The following is a description of a gene set: studied in species Homo sapiens Genes up-regulated in comparison of naive B cells versus plasma cells from bone marrow and blood. Immune cell-specific expression is one indication of the importance of a gene's role in the immune response. In order to identify such patterns, we set out to broadly profile gene expression in a variety of immune cells. Human Gene Set: GSE22886_NAIVE_BCELL_VS_BM_PLASMA_CELL_UP from publication Abbas AR, Baldwin D, Ma Y, Ouyang W, Gurney A, Martin F, Fong S, van Lookeren Campagne M, Godowski P, Williams PM, Chan AC, Clark HF (PMID 15789058), and this is the list of marker genes: ZNF682, SLA, DCAF17, ZFP36L1, GGA1, DENND4B, MDN1, MRPL39, UNC119B, SLC25A24, HHEX, RPS29, WDR48, NUP205, ARIH1, RADX, NHLRC2, LYST (lysosomal trafficking regulator), MYNN (NCBI Gene Id 55892), GABBR1, UTP14C, DTX4, TPCN1, SMC2, CHL1, MLLT10, PLSCR3, SUPT16H, XYLT1 (xylosyltransferase 1), GMCL1, HLA-DMB, CEP43, VAV3, MS4A1, MRE11, EFCAB14, WDR37, PVRIG, TSEN2, PNRC2, PARG, RPL37A, ARAP2, SOBP, CLEC4A, KIF21B, SART3, NR3C2, SPG7, FBXO28 (F-box protein 28), GSPT2, LTB, DGKZ, BTG1, IRF8, UGDH, TIPRL, SEPTIN9, POLDIP3, NAA40, ZCCHC2 (zinc finger CCHC-type containing 2), STX6, ZNF468, ALKBH1, PKIG, MAVS, CR2, CCP110, STK4, PEG10, HPF1, POT1, VAPB, EGLN2, FCMR, NBPF10, ARHGAP19, TGFBR1, ZNF112, HLA-DMA, LBH, DNAJC16, CD52, HLA-DRB1, ESS2, TPK1, SMAD3, DPYD, SGPL1, R3HDM4, PKIA, CD72, KAT6A, CREM, SELL, FBXO42 (F-box protein 42), RPL27, STAT6, DPPA4, CPEB3, TRIP4, ARHGAP45, OTUD3, PEX7, CD200, MCUB, TRIB2, SGPP1, TCL1A, AKAP11, PLPBP, TIMELESS, RBM8A, ENTPD1, ITPKB, ATP6V1B2, COMMD8, SMARCA2, TERF2, RPS6, PARN, NUP37, SBNO1, CXCR4, VPS72, TRMT2B, KYNU, MTHFD1, HLA-DRA, STRN3, GCA, MMP2, PHC1, PIK3C2B, PIK3CD, NEK9, MCM2 (NCBI Gene Id 94687), EVL, HLA-DPB1, LY86, EML4, GPRASP1 (NCBI Gene Id 9737), PRIM1, HLA-DPA1, IRS1, CDK19, MINK1, SOS2, BBS10, PLCXD1, ZNF264, CD22, CAT, LAPTM5, INPP5D, ZNF43, FASTKD2, OXSR1, LMNB1, ZNF532, DDR1, SCLY, ENDOD1, PRKCB, ZNF267, BCL10, CLCN4, ARHGEF7, UBR7, NSL1 (NSL1 component of MIS12 kinetochore complex), TSPYL5, ITPR1, SIN3B, SLC6A16, TXNDC9, MMD, RPL41, FAM53B, CD83, KCTD20, SZT2, IL4R, GIN1, UTP25, NASP, CRLF3, SFN, CORO1A, NOTCH2, RPS27, CRYBG1, LRBA, NFYB, MANBA, GPM6A, INTS9, RPL38, FRYL, NIPBL, RPS23